The following is a description of a gene set: Combining with a signal and transmitting the signal from one side of the membrane to the other to initiate a change in cell activity by catalysis of the reaction: ATP + a protein-L-tyrosine = ADP + a protein-L-tyrosine phosphate. Human Gene Set: GOMF_TRANSMEMBRANE_RECEPTOR_PROTEIN_TYROSINE_KINASE_ACTIVITY species: Homo sapiens, and this is the list of marker genes: DDR1, EPHA7, DDR2 (NCBI Gene Id 4921, discoidin domain receptor tyrosine kinase 2), KDR, EPHB3, FGFR3, FGFRL1, DGKQ, FGFR4, ROR1 (NCBI Gene Id 4919), NGF, EPHB4, VEGFA, MET, IGF2, ALKAL1, MST1R, MUSK, ROS1, RET, HBEGF, FLT3, FGFR2, IGF1R, EPHA3, INSR, EPHB2 (NCBI Gene Id 50980), TIE1, EREG, FLT4, EPHA6, EGF, EPHB1, EPHA4, NRG1, GREM1, TEK, NTRK3, EPGN (NCBI Gene Id 255324), PDGFRA, FGFR1, TYRO3, EFNA3, MERTK (MER proto-oncogene, tyrosine kinase), EPHA5, NTRK1, IGF2R, ERBB2, KIT, CRIM1, EPHA10, PDGFRL, ANGPT4, ALKAL2, NRP2, EPHA2, ERBB4 (erb-b2 receptor tyrosine kinase 4), LTK, AREG, INSRR, EPHA1, AXL, EGFR, EPHA8, NTRK2, LILRB4, FLT1, EPHB6, RYK, EFNB3, CSF1R, ROR2, NRP1, EFNA5, IGF1, BTC, PDGFRB (NCBI Gene Id 5159), ALK, EFNA4, TGFA, EFEMP1, NRG3